Given this list of marker genes BRD4, SLC1A4 (NCBI Gene Id 6509), SLITRK1, EEF1A2, VPS13A, RFX7 (NCBI Gene Id 64864), here is a description of the gene set: A phenomenon in which persons repetitively pull out their own hair, resulting in noticeable hair loss. Hair-pulling species: Homo sapiens Human Gene Set: HP_HAIR_PULLING